The following is a description of a gene set: from publication Gil MP, Ploquin MJ, Watford WT, Lee SH, Kim K, Wang X, Kanno Y, O'Shea JJ, Biron CA (PMID 22968462) Human Gene Set: GSE40666_UNTREATED_VS_IFNA_STIM_STAT1_KO_CD8_TCELL_90MIN_DN studied in species Homo sapiens Type 1 IFNs can conditionally activate all of the signal transducers and activators of transcription molecules (STATs), including STAT4. The best-characterized signaling pathways use STAT1, however, and type 1 IFN inhibition of cell proliferation is STAT1 dependent. We report that type 1 IFNs can basally stimulate STAT1- and STAT4- dependent effects in CD8 T cells, but that CD8 T cells responding to infections of mice with lymphocytic choriomenigitis virus have elevated STAT4 and lower STAT1 expression with significant consequences for modifying the effects of type 1 IFN exposure. The phenotype was associated with preferential type 1 IFN activation of STAT4 as compared to STAT1. Stimulation through the TCR induced elevated STAT4 expression, and STAT4 was required for peak expansion of antigen-specific CD8 T cells, low STAT1 levels, and resistance to type 1 IFN-mediated inhibition of proliferation. Thus, a mechanism is discovered for regulating the consequences of type 1 IFN exposure in CD8 T cells, with STAT4 acting as a key molecule in driving optimal antigen-specific responses and overcoming STAT1-dependent inhibition of proliferation. Genes down-regulated in CD8 T cells with STAT1: untreated versus interferon alpha., and this is the list of marker genes: SULT1B1, ZNF490, AGPAT5 (NCBI Gene Id 55326), DDIAS, TNRC6C, IKZF2, GTF2I, STAP1, ENSG00000286546, APP, JAZF1, ZHX3, TCL1A, CAAP1, TCTN1, CTNND1, ANKRD50 (ankyrin repeat domain containing 50), SOBP, NFKB1 (NCBI Gene Id 4790), NRIP1 (NCBI Gene Id 8204), ZNF546 (NCBI Gene Id 7600), ENC1, SEMA3D, TMEM263, BLOC1S4, SIPA1L1, POLA2, ZNF880, ZCCHC7, SENP3, CD40, FLACC1, SARAF, HYCC1, CNKSR2, ICAM2, CDCA7L, ALOX5AP, C1orf162, RAD23B, CR2, P2RX1, GLCCI1, TMEM71, CAMK2D, CCR7, JARID2, FPGS, SLC38A11, CALCRL, ZC3HC1, TMLHE, FCER2, SUPT6H, GPR160, IGF2R, IFT172, SELPLG, SERPINB9, UBL3, PAIP2B, PIK3IP1, USF3, ENAH, ENPP1, IRF2 (NCBI Gene Id 3660), CD207, CHD3, TAPT1, ZNF229, BOD1, NREP, MAML3, UBE2E2, GARRE1, ZNF471, SLC4A8, IFT122, PLEKHA2, CLN6, MIR223 (microRNA 223), SLC38A1, NUFIP1, PLEKHF2, SNX27, ACAD10, SERPINI1, IL21R, CPSF7, HSF5, SAYSD1, PRICKLE1, GBP4, WWC3, CLCN4, TENT5A, LAPTM5, SAV1, ATP10D, GPAA1, HS3ST3B1, FANCB, BACH2, NAT10, BCL6, NCK2, CPD, GCNT1, TCL1B, ABCB1 (ATP binding cassette subfamily B member 1), DPYD, DHX40, BLOC1S6, BLOC1S2, TSPAN13, HS2ST1, SNRK, ZNF415, UBE2R2 (NCBI Gene Id 54926), FLT1, PLEKHA1, HVCN1, CD72, SESN1, ADARB1, TRPS1, CEMIP2, TSPAN3 (NCBI Gene Id 359934), TREML2, HILPDA, MEF2C, PIK3C2B, NETO1, SLAMF1, TOP3A, RAB30, PECAM1, IRF4, BTG1, NFATC3, ZNF318, APOBEC3D, KCNG1, EPB41L2, FAM53B, DHX30, NDUFV3, FAM111B, ANKRD16, ZNF492, ARHGAP32, CHML, CCNG2, SH3BP2, MMD, BTBD3, SYT17, SEMA4A, SKAP1 (NCBI Gene Id 8631), APLP2, SLC39A8, HPSE, ST3GAL1, BRAF, XKRX, FAM234B, NIPAL4, PHLDB2, MOB3B, TCL6, OGFRL1, BTLA, PPFIBP1, CERS4, CHRAC1, CRIP3, CD22, BEND5, IL4R, SPPL3, THRB, UXS1, APOBEC3F, RANBP10, PRCP, FOXP1, TBC1D1, STRADB, ABCB4, BCL11A, SPRY1, BMP2K, ZNF135, FCRL1, PLPP5, VAV3, MYO1B (NCBI Gene Id 92451), CD38